The following is a description of a gene set: Human Gene Set: GOBP_CHORIO_ALLANTOIC_FUSION species: Homo sapiens The cell-cell adhesion process in which the cells of the chorion fuse to the cells of the allantois., and this is the list of marker genes: BMP5, ZFP36L1, LEF1, WNT7B, CCN1, DNAJB6 (NCBI Gene Id 9186), BMP7